Given this list of marker genes HSPA1A, RPS6KA4, C3, MZB1, GTDC1, EIF4G1, AIFM2, GSTA3, HCK, SLC11A1, U2AF1, SLC6A12, PSMB3, EHD1, PRELID2, MET, AHI1, USO1, SAP18, TMEM208, RASGRP1, AGTRAP, CYB5B, KLHDC10, DRAM1, ZC3H12C, MRPL16, TRAF1, IRF7, GTF2E2, PUS1, ALAS1, AARS1, SNORD89, CYBB, MS4A15, C18orf32, PSMC2, GSAP, SREBF1, THOC6, STUB1, TKT, PGLS, HCCS, TRAPPC6A, PSMB8, NAA38, PDE6D, JPT2, PTGES, FBL, TRAF2, LY6E, PPP1R21, GRWD1, MCM5, GSTM1, EIF6, PIK3R5, CAMP, VARS1, BLVRB, UBE2F, LRRC8C, ATP5MC3, GFOD1, GAPDH, PSMD13, OPA3, SPG7, PAG1, LRMDA, AOAH, MCRIP2, MTURN, BST1, CS, MCOLN2, MRPL54, MVK, MKKS, SNX10, SEMA3C, RNF128, SIGLEC7, PARP3, TTC13, TNFRSF1B, ENPP3, NSDHL, TTPAL, SLC16A3, ATP6V1E1, IRAK3 (NCBI Gene Id 11213), CD14, TNFAIP3, METAP1 (methionyl aminopeptidase 1), BIRC3, JMJD6, NUDT3, SLC31A1, MRPL52, SDHB, AGPAT4, IRF1, MAGT1, ST7, CIAPIN1, MRPL49, MAP2K1, KRI1, C9orf43, CCL17, MICOS10, GPAT3, TRAPPC10, USP10, ACAA1, PGK1, RIOK3, TGM2, SEC24D, ATOX1, COPE, RRAS, MRPL11, GMPPB, RASGRP4, S100A10, ARG1, COQ7, DUSP4, UPB1, LSM6, DLST, ZDHHC21, MLLT6, BCL3, NDUFA10, MTHFD2, AP4S1, EIF3B, RAB20, GBP2, TXN2, PPRC1, NSUN2, NFKBIE, SMARCB1, CMKLR1, SRC, CRNKL1, PKM, ATG9A, SNRPA1, NOL11, FAM20C, CUL2, NME1, VAMP8, PCID2, FILIP1L (filamin A interacting protein 1 like), GPI, LY6H, PSMD3, AEN, LRPPRC, DDX39B, TMEM14C, DNER, DOHH, SMYD5, MAGOHB, TMCO6, FAM98B, NR1H3, C1QBP, L3MBTL2, FLNA, PILRA, ADAM17, CTSZ, PUM3, NUDT2, PSMB9, ALG9, SEPTIN11, PFKP, PLEKHA8, JAK2 (NCBI Gene Id 3717), NADK, MGAT4A, LAYN, IL1B, PCDH7, WDR75, MRPS11, MCEMP1, HSD17B12, here is a description of the gene set: Genes down-regulated in plasmacytoid dendritic cells (4 days after knockout): wildtype versus TCF4 knockout. The interferon-producing plasmacytoid dendritic cells (PDC) share common progenitors with antigen-presenting classical dendritic cells (cDC), yet they possess distinct morphology and molecular features resembling those of lymphocytes. It is unclear whether the unique cell fate of PDC is actively maintained in the steady state. We report that the deletion of transcription factor E2-2 from mature peripheral PDC caused their spontaneous differentiation into cells with cDC properties. This included the loss of PDC markers, increase in MHC class II expression and T cell priming capacity, acquisition of dendritic morphology and induction of cDC signature genes. Genome-wide chromatin immunoprecipitation revealed direct binding of E2-2 to key PDC-specific and lymphoid genes, as well as to certain genes enriched in cDC. Thus, E2-2 actively maintains the cell fate of mature PDC and opposes the “default” cDC fate, in part through direct regulation of lineage-specific gene expression programs. Human Gene Set: GSE24726_WT_VS_E2_22_KO_PDC_DAY4_POST_DELETION_DN from publication Ghosh HS, Cisse B, Bunin A, Lewis KL, Reizis B (PMID 21145760) studied in species Homo sapiens